The following is a description of a gene set: Abnormal femoral torsion Femoral torsion, also known as femoral rotation or femoral version, refers to the twist between the proximal and distal parts of the femur on the transverse plane. Femoral anteversion averages between 30-40 degrees at birth, and between 8-14 degrees in adults. This term applies if the amount of femoral torsion deviates from this range. studied in species Homo sapiens Human Gene Set: HP_ABNORMAL_FEMORAL_TORSION, and this is the list of marker genes: MADD, FIBP (FGF1 intracellular binding protein), P3H1, UBAP2L, SLC26A2, ACTB, PI4KA, CRTAP, GABBR1, KIFBP